Given this list of marker genes Aoc3, Aoc1, Etfdh (electron transferring flavoprotein, dehydrogenase), Aoc2, Ndufs2, mt-Nd4, Dhodh, Ndufs7, Cbr4, Sdhd, Vkorc1, Coq10b, Vkorc1l1, Sqor, Hsd17b8, Sdhb, here is a description of the gene set: Binding to a quinone, any member of a class of diketones derivable from aromatic compounds by conversion of two CH groups into CO groups with any necessary rearrangement of double bonds. species: Mus musculus Mouse Gene Set: GOMF_QUINONE_BINDING